The following is a description of a gene set: species: Mus musculus A nine-bladed, propeller-like protein complex that links the distal end of the basal body and the cilium to the plasma membrane. Functions in protein sorting and gating (i.e. active and passive transport of proteins in and out of the cilium). Mouse Gene Set: GOCC_CILIARY_TRANSITION_FIBER, and this is the list of marker genes: Sclt1, Tchp, Fbf1, Cep83, Dzip1, Cep89, Cep164 (centrosomal protein 164), Cenpf, Odf2, Nin